Given this list of marker genes PPM1K, BCKDHA, DBT, BCKDHB, DLD, here is a description of the gene set: Human Gene Set: REACTOME_MAPLE_SYRUP_URINE_DISEASE Maple Syrup Urine Disease studied in species Homo sapiens